The following is a description of a gene set: from publication Bruins W, Bruning O, Jonker MJ, Zwart E, van der Hoeven TV, Pennings JL, Rauwerda H, de Vries A, Breit TM (PMID 18195040) species: Mus musculus Early-late response genes: differentially expressed in the first 3 h and after 12 h following UV-C irradiation of MEF cells (embryonic fibroblast). Phosphorylation is important in p53-mediated DNA damage responses. After UV irradiation, p53 is phosphorylated specifically at murine residue Ser389. Phosphorylation mutant p53.S389A cells and mice show reduced apoptosis and compromised tumor suppression after UV irradiation. We investigated the underlying cellular processes by time-series analysis of UV-induced gene expression responses in wild-type, p53.S389A, and p53(-/-) mouse embryonic fibroblasts. The absence of p53.S389 phosphorylation already causes small endogenous gene expression changes for 2,253, mostly p53-dependent, genes. These genes showed basal gene expression levels intermediate to the wild type and p53(-/-), possibly to readjust the p53 network. Overall, the p53.S389A mutation lifts p53-dependent gene repression to a level similar to that of p53(-/-) but has lesser effect on p53-dependently induced genes. In the wild type, the response of genes to UV irradiation was strictly biphasic. The early stress response, from 0 to 3 h, results in the activation of processes to prevent the accumulation of DNA damage in cells, whereas the late response, from 12 to 24 h, relates more to reentering the cell cycle. Although the p53.S389A UV gene response was only subtly changed, many cellular processes were significantly affected. The early response was affected the most, and many cellular processes were phase-specifically lost, gained, or altered, e.g., induction of apoptosis, cell division, and DNA repair, respectively. Altogether, p53.S389 phosphorylation seems essential for many p53 target genes and p53-dependent processes. Mouse Gene Set: BRUINS_UVC_RESPONSE_EARLY_LATE, and this is the list of marker genes: 1110059E24Rik, ENSMUSG00000134760, Mycl (NCBI Gene Id 16918), D6Wsu163e, Ppp1r11, Snx10, Nipbl, Slx4ip, Fubp1, 5830454E08Rik, Hnrnpll (heterogeneous nuclear ribonucleoprotein L-like), Smap1, 2310001H17Rik, Msrb2, Ift27, Shmt2, Med10, Anxa3, Zfp281, Tmem88, Irgm1, Rab3ip, Neb, Yaf2, Nscme3l, Col6a4, Gucy1b2, Spry2 (NCBI Gene Id 24064), Ubn1, Zbtb25, ENSMUSG00000133486, 1700018B08Rik, Ankrd11 (NCBI Gene Id 78664), Emsy, Nxph3, Ahrr, Plat, Ptpn2, Rps20 (ribosomal protein S20), 1700095J07Rik, Dnaaf2, Gpx3, Anapc15 (NCBI Gene Id 75430), Mta3 (metastasis associated 3), Magef1, P2ry12, Rplp0, Dgat1, Cdyl, Znrd2, 1700008C04Rik, 4930455B14Rik, Map2, Rad18, Vps37b, Ube2w, Hdac9, Atoh8, Frmd4a, Hcfc2, 1110019D14Rik, 1700047G07Rik, Sec22a, Ddhd1, Tubd1, Chordc1, 4930566N20Rik, Sptlc2, Snhg9, Siva1, Atg3, Tmem248, Stambpl1, Ptpn12 (protein tyrosine phosphatase, non-receptor type 12), Ccdc6, Aplf, Casp8ap2, Exo1, C8b, Cstf3, Lrr1, Smad6, 3300002P09Rik, Rnf115, Dhx33 (DEAH-box helicase 33), Ces2c, Pgm2, Filip1l (NCBI Gene Id 78749), Rbm38, Rlig1, Mup10, Desi2, Unc80, Tmem223, 0610009L18Rik, Crtc3, Ppp1r15b, Eif1a, Prickle2, Apobec1, Ncoa6, Abcd3, Trex1, Nectin2, Map4, Rps17, Tubb4b, Ahnak, Zfand1, Arl6ip6, Cemip, Tafazzin, Cln8, Slit1, Trappc2, Acvr1, Mtif2, Socs3, Snap23, Rab25, Chd2, Ebag9, Fam228a, Ssb, C330018D20Rik, Aplp1 (amyloid beta precursor like protein 1), Rilpl1, Epha4, Emc9, Osbpl6 (oxysterol binding protein-like 6), Tor4a, Pmvk, Tgds, Ulbp1, Dennd1b, Pmfbp1, Trim26, Igf1r, Qki, Rmdn3, Kcnk2, 2610507I01Rik, 4930429P21Rik, Dusp16, Kcne3, ENSMUSG00000137581, Dyrk2, Gmnn, Grik2, Camk2n2, Mitd1, Ctrc, Insig2, Ss18, Ndfip2, Ifrd1, 4933424G05Rik, Tom1l1, Ppp2r2d, 4930547E14Rik, Sema6c (sema domain, transmembrane domain (TM), and cytoplasmic domain, (semaphorin) 6C), E2f3, Srrm2, Ccne2, Yju2b, Slc1a2, Arid1a, Ntf3, Camkk1, Chchd6, Zfp264, Fes, Prdm5, Pter, Wac, Pcgf6, Rassf5, Map1a, Zc3h6, 2410018L13Rik, Slc30a6, Macrod1, Cdc40, 4930484H19Rik, Nmnat3, 9530077C14Rik, Cyp26a1, Tceanc2, Cish, 1700084F23Rik, Trim6, Smc6, Lmbrd1, Dlg3, Abraxas1, Kpna3, Ska2, Tuft1, Mob4, 4930594A02Rik, Stil, Rnf216, Tinf2, Micos13, Smc3, Uvssa, Tulp3 (NCBI Gene Id 69552), Asap1, Dusp12, Etv5, Prss3b, 1700015C15Rik, Actrt3, Pkp2, Fbxo5, Cd84, Zc3hc1, Mvb12b, Kcmf1, Pdzrn3, Pik3cb, 4930442G15Rik, Pum1, Tgfbrap1, Sgcg, Kdm1a, Ect2, Nup37, Thumpd2, Snord55, Macrod2, Mvd, 4930479D17Rik, Mlh3, Calm3, Ttn, Spef1, Mettl5os, Foxk2, Nip7, Lpcat1, Rras2, Ctdspl, Stag2, 1700028D13Rik, Ppm1f, Lrp1, Brme1, Uimc1, Psmc6, Sting1, Wdsub1, Fbxo42, Fbxw11, Txndc16, Exosc7, Cdt1, Aunip, Rpp21, Atrx, Rora, Polr1has, Clpp, Snx24, Msantd3, Tcp10b, Pinx1, Arhgdig, 1700113B19Rik, Nr2c1, 1700010G06Rik, Dusp14, Zbtb4, Rpsa, Smurf2, Tcl1b3, Akirin2, Hspbp1, Rmnd1, Gfi1, Nme4, Phf3, Usf2, Arhgef18, Six3, Aatk, Banf1, Tbx15, Sorbs1, 4930422I22Rik, Ints3, Rnf111, Zcchc8 (NCBI Gene Id 70650), Pou2f2, Aspscr1, Epc1, 2410002F23Rik, Ptcd2, Gpcpd1, E2f6, Snhg20, Plcd3, Eif3a, Nosip, Ube2g1, Gas8, Stk10, Fra10ac1, Faf2, Zcchc14, Urm1 (ubiquitin related modifier 1), Tada2a, Mat2b (methionine adenosyltransferase 2 non-catalytic beta subunit methionine), Ubl4a, Dusp28, Nenf, Evpl, Lrig1, Cxcr6, Nasp, 4930421C12Rik, Llcfc1, Slc4a1ap, 1700102P08Rik, 2900093K20Rik, Lnx2, Mapk1, 4933407I05Rik, Traf2, ENSMUSG00000124799, Rnd3, 4930511E03Rik, Rbm6, Ublcp1, Alkbh8 (alkB homolog 8, tRNA methyltransferase), Lsm1, B9d1, Arih1, Ctdp1, Stx17, Nat8f1, Sec24b, Schip1, Has2, Bcar3, Psmg2, Ccdc124, Zmynd8, Cald1, Dtwd1, 2310002F09Rik, Nudt7 (NCBI Gene Id 72279), 1810019D21Rik, Actr8 (ARP8 actin-related protein 8), 4921524J17Rik, Gfra4